The following is a description of a gene set: The chemical reactions and pathways involving pyrimidine nucleoside triphosphate, a compound consisting of a pyrimidine base linked to a ribose or deoxyribose sugar esterified with triphosphate on the sugar. Mouse Gene Set: GOBP_PYRIMIDINE_NUCLEOSIDE_TRIPHOSPHATE_METABOLIC_PROCESS species: Mus musculus, and this is the list of marker genes: Nme4, Tyms, Ctps2, Entpd7, Ctps1, Dtymk, Ak3 (adenylate kinase 3), Tbpl1, Uck1, Nme1, Uck2, Nme2, Dctpp1, Dut, Entpd4, Nme7, Nme6, Nme5, Cmpk2, Nme3, Entpd4b, Cad